The following is a description of a gene set: Human Gene Set: HP_BULBOUS_NOSE Increased volume and globular shape of the anteroinferior aspect of the nose. studied in species Homo sapiens Bulbous nose, and this is the list of marker genes: CIT, KMT2D, POU4F1, SMARCD1, PGAP3, CDK19, TOMM7, SMS, TWIST2, CUL4B, STXBP1, CUX1, MRAS, PIGV, ALG3, LMX1B, PGM2L1, ECE1, KDM5B, KANSL1, PQBP1, EXTL3, RAP1B, HIRA, CDK13, MED12, AP4B1, SHANK3, SNIP1, KMT2B, MED12L, TCF20, ZNF292, UBAP2L, SETD5, EXT1, SMC5, TRRAP, POR, DGCR6, PIGY, KCNN3, MPDZ, AGO1, SRD5A3, QRICH1, RNU4-2 (RNA, U4 small nuclear 2), SMG8, MESD (NCBI Gene Id 23184), TRPM3, CDH11, COL1A2, CAMTA1, DOCK6, EXT2, ATN1, SMPD4, ACTL6B, FMR1, NANS, CDC42, CCNQ, TBC1D24, ABCA5, CEP55, MED13L, GJA8, FBN1, SMC3, SCAF4, CLP1 (NCBI Gene Id 10978), SLC25A46, KIFBP, UFD1, MIPEP, DYNC1I2, SLC35C1, HECW2, RREB1, WAC, SPOP, MTX2, COL18A1, RUSC2, CEP57, COL11A2, DYRK1A, TBX4, TUBGCP2, CNTNAP2, SPRTN, AFF3, SOX5, TBC1D23 (TBC1 domain family member 23), AP4E1, GJA5, ECEL1, CLPB, KCNJ5, AP4S1, SRRM2, LTBP3, MAN1B1, JAG1, PACS1, BBS2, NKX6-2, KCNJ2, ATP6V1B2, DOCK7, CSF1R, PYCR2, CPT2, SEC24C, MMP2, PIGL, TBX1, ALDH1A2, FRA10AC1, TONSL, KAT6B, NHEJ1, SPEN, USP9X, UNC80, BRAF, KIF15, SMARCA2, ASXL3, ESS2, DDX3X, HUWE1, MBD5, JMJD1C, SNX14, WDR62, STAG2, DGCR8, SPTBN1, PGAP2, EIF5A, ALDH6A1, PIGO, KAT5, CCDC8, EDEM3, ACTB (actin beta), PYCR1, FREM1, KATNB1, RAP1GDS1, AP4M1, CUL7, FOXG1, RAD21, TBCK, RNU4ATAC, KMT2A, SRCAP, CCDC47, MYT1L (NCBI Gene Id 4662), HK1, SLX4, CPLX1, JARID2, DGCR2, CLIC2, TRPS1, SATB2, SMARCAL1 (NCBI Gene Id 50485), GP1BB, KCNH1, MYO18B, H4C5, COMT, ATP6V1A, EFEMP2, ZFX, ARVCF (ARVCF delta catenin family member), SIM1 (SIM bHLH transcription factor 1), EBP, TRAF7, ZMYM2, BICRA (BRD4 interacting chromatin remodeling complex associated protein), ESAM (endothelial cell adhesion molecule), INTS1, TRIO, SC5D, FBXO31, SCYL2, ODC1, PIGW, MAP3K7, C2CD3, CLCN3, FBXL3, TAF1, KDM4B, YY1, RERE, DLX4, RBMX, FBXO11, OBSL1